The following is a description of a gene set: Fibrotic response of human trabecular meshwork cells to transforming growth factor-beta 3 (TGFB3 and autotaxin (ENPP2, or ATX) in aqueous humor Human Gene Set: WP_FIBROTIC_RESPONSE_OF_HUMAN_TRABECULAR_MESHWORK_CELLS_TO_TRANSFORMING_GROWTH_FACTORBETA_3_TGFB3_AND_AUTOTAXIN_ENPP2_OR_ATX_IN_AQUEOUS_HUMOR studied in species Homo sapiens, and this is the list of marker genes: MAPK8, FN1, TGFB1, RHO, SMAD3, MAPK10, TGFB3, ENPP2, CCN2, STAT3, LPA, COL1A1, ACTA2, MAPK9, TGFB2